Given this list of marker genes TPSAB1, NPY1R, DYRK3, MNDA, GAS6, GPX1, AZGP1, ADRA2A, ADORA2A, IFI27, CSF3, CCL7 (NCBI Gene Id 6354), DEFB1, CLEC2B, DAPK1, CSF3R, CCL18, CCR2, MPO, CD3G, CEACAM1, CD79A, CXCR2, CD8A, MAP3K8, GATA3, LILRB5, CHRM3, IL24 (NCBI Gene Id 11009), CNR2, C5AR1, CD69, CD24, APOE, OAS1, IL6ST, HLA-A, LTF, CFB, AKR1C3 (NCBI Gene Id 96424), IRF7, CX3CR1, LILRB3, GPR65, GRK1, TFF1, C4BPB, CD14, REG1B (regenerating family member 1 beta), IL2RG, ALCAM, PTMS, FN1, EPHX1, LTA (lymphotoxin alpha), MDK, CXCL13, IL4R, C7, IL3RA, IL1R1, TIMP1, CCN2, IGLL1, HLA-DMB, GALR3, IFIT1, C8B, FCGR2A, CD48, C8G, KIR3DL1, CCL23, PAX5, C1S, FCGR3B, FCGR3A, MST1R, TACSTD2 (NCBI Gene Id 4070), H1-2, TNFSF12, FGF7, LILRA1, GBX2, LGALS3BP, CCL11, C5, TEK, CCL20, PTAFR, NRP1, HLA-DRB5, NR4A2, CTSC, GSTA3, HP, SFN, LY6H, CST7, FCN2, SERPING1, CD1C, MGST3, ERG, MYLK, FGF6, CD53, RAG1, CD55, CCL1 (C-C motif chemokine ligand 1), CCL4, NPY, VTN, AGRP, STAT1, TIRAP, HLA-DRA, TNFRSF13B (TNF receptor superfamily member 13B), PDGFA, IGSF6, AIF1, CD86, CD59, CD101, NAB2, TGFA, CSF1, EMP3, F2, P4HA2, KIR2DL4 (killer cell immunoglobulin like receptor, two Ig domains and long cytoplasmic tail 4), MS4A2, IL11, MTHFR, GEM, BPI, ISG15, CD72, HLA-B, NAMPT, FGA, C2, IL6R, PDGFB, CRIP1, CD247, IFI44, IL18, CX3CL1, CXCL2, HBEGF, TNFSF10, LCP2, PF4, SEMA3C, LST1, KLRK1, CD22, ITGB2, CXCL11, EGF, PSPHP1, LILRB1, CCL8, LIF, GZMA, CCR1, CCL13, CXCL14, IL1RAP, CTSS, CCL21, F8, GPX2, DNAJC3 (DnaJ heat shock protein family (Hsp40) member C3), PRG2, AIM2, C1QA, IFIT5, CD6, PSMB9, NCF4, DEFB4A, CR2, CSF2RB, IL16, CD300C, LY86, CD8B, LILRA2, FAS, CFI, NQO1, MYC, CD3D, IFITM1, IL27RA, HLA-F, CFHR1, KLRC1, PDCD1, ISG20, AHR (NCBI Gene Id 196), CEBPE, CCL14, SELP, CXCL1, IL15, EREG, CD81, ERBB2, C3AR1, MX2, CXCL9, IGF2, CCL15, LILRB4 (NCBI Gene Id 11006), DPP4, MXD1, FYN, MGST2, GMFG, FLT3, INSIG1, EGR4, EPHA2, CDK5R1, CD5, KLRA1P, C8A, FGG, LTB, ADM, F3, EMP2, RUNX3, IRF1, GPR183, CD2, EMP1, IL7R, C3, BTG1, FCER1G (NCBI Gene Id 2207), ST6GAL1, OSM, ZFP36L2, HFE, DAB2, LBP, LILRB2, TLR2, ZEB1, FCN1, CSRP2, PTN, CD27, PYY, CREG1, C6, BTG2, FCGRT, STAT3 (signal transducer and activator of transcription 3), CXCL6, ARHGDIB, PSTPIP1, CFH (NCBI Gene Id 3076), TGFBI, CTSG, GBP1, CD4, EVI2A, KLF6, PDGFRA, GRN, FYB1, NFKBIA, BST1, CXCL12, IFITM2, ADA, UMOD, MIA, CLU, ENDOG, EDNRA, C9, ITK, CLC, CD83, SFTPD, DEFA5, OSMR (oncostatin M receptor), SERPINF1, SELENOP, HLA-C, CD19, C1R, IRF8, UBD, PGLYRP1, LAT, SH2B2, IL15RA, MAD1L1, EPHX2, TLR1, NCF2, CCL2, SEMA4D, BCL6, GPX3, CXCL5, CCR9, IL1A, IL6 (NCBI Gene Id 3569), TNFSF11, TNFSF14, MS4A1, LAMP3, CCL19, GLYAT, BATF, SH2D1A, IGF1, CDKN1A, FCER1A, KCNN4, OASL, B2M, CD79B, ORM2, IL18R1, C4BPA, LSP1, HLA-G (NCBI Gene Id 3135), FASLG (Fas ligand), ORM1, THPO, CCR5, IFNGR1, SPOCK1, SKAP1, IL9, CR1, SNN, CXCL10, XCL1, CXCR4, CES1, FGR, GBP2, SELL, SAA1, LCK (NCBI Gene Id 95387), NCF1C, CCL3, ENPEP, TFF3, AIRE, FGB, CHIT1, CYBB, CCL17, CFP, BST2, HLA-DOA, CD5L, LY6E, PRF1, C4B, CRLF1, EPS8, CXCL8, ETS1, LRP1, PPBP, LTBR, RNASE6, MX1, IL1B, CAMP, IL2RB, TYROBP (NCBI Gene Id 7305), CCN1, GNLY, BCAT1, PTGER4, EDN1, CAPG, IFITM3, SLAMF1, S100B, GCG, AQP9, STAT5A, VIPR1, AREG, here is a description of the gene set: species: Homo sapiens Immune response. Human Gene Set: MODULE_75